Given this list of marker genes ARHGAP21, CLASP1, CADM1, LRP12, CHL1, EPB41L2, CACNA1B, GRIK2, RAP1GAP, NCDN, EPB41L3, MAP4K4, IDH3B, SPTAN1 (NCBI Gene Id 6709), EPB41, ANK3, APLP2, AGRN, STXBP2, GOLGA4 (NCBI Gene Id 2803), BPTF, EFNA5, NTNG1, CAMK2G, PTPRF, CLSTN1, GPR45, CASK, MAPK8IP1, TACC2, GPHN, GRIN1, DNAJB5 (NCBI Gene Id 25822), EPHA5, TPM3, SRR, KCNQ2, KCNMA1, LRP1B, ATP2B1, CTNNA2, PLCB4, STX2, here is a description of the gene set: Alternative RNA splicing greatly increases proteome diversity and may thereby contribute to tissue-specific functions. We carried out genome-wide quantitative analysis of alternative splicing using a custom Affymetrix microarray to assess the role of the neuronal splicing factor Nova in the brain. We used a stringent algorithm to identify 591 exons that were differentially spliced in the brain relative to immune tissues, and 6.6% of these showed major splicing defects in the neocortex of Nova2-/- mice. We tested 49 exons with the largest predicted Nova-dependent splicing changes and validated all 49 by RT-PCR. We analyzed the encoded proteins and found that all those with defined brain functions acted in the synapse (34 of 40, including neurotransmitter receptors, cation channels, adhesion and scaffold proteins) or in axon guidance (8 of 40). Moreover, of the 35 proteins with known interaction partners, 74% (26) interact with each other. Validating a large set of Nova RNA targets has led us to identify a multi-tiered network in which Nova regulates the exon content of RNAs encoding proteins that interact in the synapse. Genes whose splicing in neocortex was most affected by knock out of NOVA2. from publication Ule J, Ule A, Spencer J, Williams A, Hu JS, Cline M, Wang H, Clark T, Fraser C, Ruggiu M, Zeeberg BR, Kane D, Weinstein JN, Blume J, Darnell RB (PMID 16041372) Human Gene Set: ULE_SPLICING_VIA_NOVA2 studied in species Mus musculus